Given this list of marker genes DEAF1, CLIP2, UFSP2, ATG7, RPL8, ERCC4, HDAC8, COG1, FBN1, CSNK2A1, LBR, VPS35L, SLC32A1, FLII, EDA, TPM2, ANTXR2, CHRNA1, BSCL2, EHMT1, KMT2D, CUL7, GALNT2 (NCBI Gene Id 2590), ASAH1, CNOT3, SPARC, GABRD, TCF20, VPS37D, COL7A1, DDR2, SLC9A7, SH3PXD2B, GRIN1, KRAS, LRP4, MAN2C1, EVC2, CTSD, IRF6, DSP, SEC24C (NCBI Gene Id 9632), STX1A, FBXL3, KCNAB2, RRAS2, LONP1, UBA2, MOGS, GLB1, IKBKG, TOMM7, FRA10AC1, VPS13B, DMXL2, KLHL15, MECP2, CCNK, WRN, AKT3, PIGS, KIF1A, NKX2-5, HRAS, RREB1, TCF12, PHYH, PGAP3, VAC14, WASHC5, XRCC2, RRAS, ABL1, CEP19, ARID1B, CDKL5, COG8, RPL15, CSGALNACT1, CEP104, SETD2, LMNA, PRMT7, DHCR7, TAF4, SOS2, ZFX, GPC4, LZTR1, HTT, FGFR1, MCTP2, GGCX, BUD23, ZMPSTE24, MYSM1, UBE2T, ARID1A, IGF1, CEP152, GNB1, TUBB3, NAA20, GABBR1, PIGH, ATP7A (ATPase copper transporting alpha), TWIST2, BMPR1B, SVBP, FBLN1, SHH, CDKN1C, IFT122, ATL1, CHST11, ALG12, BRIP1 (NCBI Gene Id 83991), TOPORS, PCNT, HYLS1, DPF2, PQBP1, WDPCP, PPOX, TBX3, CAMTA1, TAF6, OGT, ZFPM2 (NCBI Gene Id 56958), MAPT, WNT5A, NSUN2, CCDC8, TXNDC15, SEMA3E, COG5, DDX11, PCDHGC4, ATR, MKS1 (NCBI Gene Id 54903), HUWE1 (NCBI Gene Id 54789), BUB1B, ASCC3, PTHLH, DLG5, FANCI, SLC25A24, RPL9, IHH, SHMT2, ADA2, GLI3, RAB34, CCDC28B, MPZ, CTNND2, FLNA, FMR1, SPRED1, RPL35, RAB3GAP1, RB1, NEPRO, FGF10, PTDSS1, TRIO, HOXA11, ARMC9, UBAP2L, HHAT, HNRNPK, ARSB, BRAF, KCTD1, IFIH1, OFD1, LHX4, EGR2, ORC1, BBS12, NOTCH1, MAPK8IP3, KPTN, NDN, HIC1 (NCBI Gene Id 3090), WWOX, SRCAP (Snf2 related CREBBP activator protein), CEP55, MMP1, AMER1, CKAP2L, RAB18, KDM6A, DDX59, TUBA1A, GTPBP2, ZNF699, TP63, ANAPC1, WIPI2, MED12, MEN1, SPART, SNORD116-1, TFAP2A, TMEM107 (transmembrane protein 107), ANKRD11, PIGL, B3GAT3, DPAGT1, ROR2, B9D1, TBX5, YWHAE, BRCA1, PRKACA, NALCN, MAPK1, FIBP, PIK3CD, AHSG, TRIP11, BAP1, ARX (NCBI Gene Id 619216), JAG1, ARHGAP31, STX16, ATP6V1B2, KCNJ2, TUBB2B, INSR, IGF2, HMGA2, CANT1, RPS29, COG4, REV3L, GAN, IFT74, GTF2IRD2, PAICS, SH2B1, NEXMIF (NCBI Gene Id 340533), ATL3, CHD8, PUM1, PHF8, FANCA (NCBI Gene Id 82952), GDF1, CNOT2, GABBR2, PPARG, CPLX1, DHPS, SON, PHIP, CDC6, BRAT1 (NCBI Gene Id 221927), WDR73 (WD repeat domain 73), TRAPPC2, CLCN7, SLC25A22, CSPP1, MEG3, CEP290, GJB6, NARS2 (asparaginyl-tRNA synthetase 2, mitochondrial), APC, TBL1XR1, BUB3, EDA2R, LEMD3, WNT7A, WDR26, RERE, CDC42, MATN3, RAD51C, TBX1, B9D2, RAB3GAP2, JUP, NANS, SLC6A17, PALB2, DNA2, GLE1 (GLE1 RNA export mediator), TMEM67 (transmembrane protein 67), GDF5, FANCD2, IQCE, COL9A3, CTBP1, CHD6, SPOP, WDR35, PCGF2, DYNC1H1, WAC, CRELD1, GJA1, UBR1 (NCBI Gene Id 64703), FZD2, ARSL, BBIP1, DPYSL5, EVC, AGO2, MEF2C, TMCO1, DYM, DONSON, AMMECR1, FOXP2, NAA10, MAF, PNKP, ERCC6, ROBO1, HSPG2, DNMT3A, CCDC32, KIF7, SF3B4, PLAG1, C2CD3, H19, SDCCAG8, CTSK, ALOXE3, PIGN, CDC42BPB, WDR81, JMJD1C, DYNC2I1, PSAP, EBP (EBP cholestenol delta-isomerase), PSMD12, INTU, CD96, ATRX, PHEX, NUP37, DCHS1, LMBR1, FLI1, INPP5E, CIBAR1, SOX6, COX4I1, RAB33B, ENPP1, PHOX2A, UBE4B, GJB2, IFT52, SLX4, FIG4, RTL1, PIGF, RUNX2, PTEN, GNAO1, SMARCD1, METTL27, SCN9A, RSPRY1, ASXL3, BHLHA9, BBS7, PTPN2, ZNF462 (zinc finger protein 462), TFE3, SMO, NGLY1, LMX1B, CWC27, SIK3, ARL3, TGDS, RPS7, SOX11, SATB2, TBL2, PAX3, DPH2, RPL5, PIBF1, ALG6, HOXD13, SMC3, GMNN, CTSC, TWIST1, MEIS2 (NCBI Gene Id 56908), DYNC2I2, TRIM32, DYNLT2B, PIGY, FANCM, TELO2, CREBBP (CREB binding protein), CHN1, NTRK1, PRDM16 (PR/SET domain 16), UNC80, RIT1, ALOX12B, TRIM8, FGFRL1, LUZP1, RETREG1, MITF, MKKS, CACNA2D1, BRD4, SCN2A, CAVIN1, PIK3R1 (phosphoinositide-3-kinase regulatory subunit 1), GPX4, GP1BB, TRPM3, NOTCH2, IL2RB, RPS24, RMRP, CBY1, PTRH2, ARCN1, EOGT, H4C3, MRAS, CDK5, PPP1R21, COASY, KCNJ5, PRKACB, SEM1, TBR1, GTF2IRD1 (NCBI Gene Id 9569), COL10A1, ADAMTS10, KDM5A (NCBI Gene Id 5927), MAP3K7, SNORD115-1, KAT8, TREX1, GLI2, KDM4B, NEUROD2 (neuronal differentiation 2), WNK3, SPTLC2, SOS1, RFWD3, ATP6V1E1, SLC52A2, FGFR2, ALG13, LRP5, FGD1, CCDC22, HSD17B4, ORC6, HEATR3, TRPS1, RPS10, RNF216, DOK7, TFAP2B, RYR3, SYNE1, CD247, FAT4, COL2A1, MEGF8, NSD2, ABCA12, GLI1, BBS5, SCN1B, COL3A1, CEP41, TNNI2, FOS, RPS20, NDRG1, STAT4, SMARCA4, CHRNG, NSDHL, RPL10, TCTN3, CNTN1, NPR2, PAFAH1B1, PHGDH, ZIC1, CCBE1, KIT, KIF5C, IQSEC2, RPGRIP1, TBX22, CEP57, NELFA, PWAR1, PLOD3, KCNK4, DYNC2H1, COL9A1, ODC1, PLXND1, GATA6, SBF2, LSS, PLK4, PTPN22, CDC45, MLXIPL, RBM10, SMARCC2, COL17A1, PMP22, LIMK1, NIN (ninein), SLC34A2, MYH3, ACTL6B, GUSB, FGFR3, CHRND, UBE3A, NUP85, ARID2, DACT1, KIFBP, AHDC1, DLX5, HERC1, IFT172, TMEM231, PRG4, USP9X, CAPRIN1, FBXO11 (NCBI Gene Id 80204), PDPN, STAMBP, EIF4A2, KCNH1, BBS4, RBM8A, IGF1R, PTF1A, NCF1, SAMD9, ACP5, GALNS, PHF21A, BRCA2, NPHP1 (nephrocystin 1), SLC35D1, FILIP1, CASK, NOG, PHF6, L1CAM, MYMX, B3GLCT, TBX4, OTUD5, YY1AP1, WNT10B, RPL26, ASPH, KLF13, ELN, CRKL, ABCC6, TMEM237, RAD21, CDH3, AIP, CFAP418, RNF13, SMG9, SF3B2, BGN, GNAS-AS1, KRT1, CCN2, NSD1, FLT4, PIGO, SLC35B2, BBS9, LETM1, ERF, ZNF292, CAMK2G, BBS10, RECQL4 (RecQ like helicase 4), QRICH1, MAP3K20, H3-3B, LHX3, ERCC8, ADGRG6, WDR4, KDR, AKT1, SNRPN, SMARCA2, PRKAR1A, SHANK3, KIAA0753 (NCBI Gene Id 9851), IFT27, CHUK, MADD, KDM5C (NCBI Gene Id 8242), MMP2, ACVR1, BAZ1B, SCYL2, MYBPC1, MBTPS2, PIGV, DNAJC30, PTCH1, KDM6B, FANCG, RIPK4, MAX, BLM, GNAS, EXT2, MACROH2A1, SCNM1, ACOX1, CILK1, RAI1, ABCC9, GNB2, PIK3R2, TBC1D24, KRT5, TGM1, ACTB, HNRNPH1 (NCBI Gene Id 3187), MYMK, KMT2B, MKRN3, MMP23B, NKX2-6, ZMYM2, FERMT1, SCAPER, HOXA13, SMARCB1, MAFB, PIGG, OPA3, RNU4-2, SIN3A, TOR1A, SCARF2, SOX4, SALL4, BCOR, CCND2, STAG1, CLDN16, DPM1, BTRC, ORC4 (NCBI Gene Id 5000), RPS27, EFNB1, GATA4, MBD5, PEX6, BPTF, GNPNAT1, ZNF141, IFT80, ZC4H2, SETBP1, MAGEL2, ADNP, SMAD4, MTOR, COL11A1, LTBP3, DOCK6, SC5D, DHODH (NCBI Gene Id 1723), CTDP1, AHI1 (Abelson helper integration site 1), NTNG1, LMNB2, MORC2, GNPTAB, FANCL, GPR101, AFF4, FBXO28, FLNB, PIGW, PPM1D, ZBTB20, BRF1, IFT57, ATP2B1, RAD51, INPPL1, FGF16, RPL31, SATB1, RPGRIP1L, HINT1, NEDD4L, BICRA, BMP6, ARVCF, BLTP1 (bridge-like lipid transfer protein family member 1), KCNA1, ARL13B, NRAS, SUFU, SIK1, BCR, ALDH18A1, IDS, CTCF, KDM1A, GRIK2, POC1A, CNTNAP1, PPP2R3C, ACBD6, NEK1, POU1F1, ACAN, DYNC2LI1, TNNT3, CBFB, BMP4, CAV1, ERI1, ADAMTS15, CPLANE1 (ciliogenesis and planar polarity effector complex subunit 1), BPNT2, LAMA3, TRIP13, WDR11, EZH2, HNRNPA1, STAG2, FRAS1 (Fraser extracellular matrix complex subunit 1), POR, RNU4ATAC, TRAIP, MMP14, KAT6B, CENPE, ZSWIM6, RASA2, PRKDC, EXOC6B, PACS1, HFE, FANCC (FA complementation group C), COG7, TMEM216, ADAMTSL2 (ADAMTS like 2), PIK3C2A, USP7, PDGFRB, SLC2A10, PROP1, TRPV4, SCUBE3, TGFBR1, SUZ12, BANF1, PTPN11, TMEM218, DVL1, ALDH1A2 (aldehyde dehydrogenase 1 family member A2), MYL11, PIGA, KIAA0586, LZTFL1, PACS2, SDHB, RBPJ (recombination signal binding protein for immunoglobulin kappa J region), AUTS2, GPC3, RECQL (RecQ like helicase), SLC6A9, WDR19, NIPBL, ATRIP (ATR interacting protein), LAS1L, NR4A2, TCF4, EIF4A3, PAH, TPR, RPS19 (ribosomal protein S19), CNOT1, SLC26A2, SDHC, RAB23, EIF2AK3, TBCE, TTC8, GRM7, HSPB1, ITGB6, MIA3, EXT1, PRIM1, HEPACAM, TONSL (NCBI Gene Id 4796), COMT, LAMA5, KIDINS220, MRPS28, RAF1, EXTL3, EN1, RPS6KA3, SIAH1 (NCBI Gene Id 6477), BBS1, LAMC2, KIF21A, AFF2, NFIX, CCDC47, ATN1, DLL4, AGPAT2, CUL3, ESCO2, HESX1, HIRA, EIF4H, PKDCC, TRAPPC9, MSL3, PRR12, PIEZO2, RBBP8, TMEM270, SEMA5A, SIL1, FAM149B1, CDK10, TOGARAM1, MYOD1, SMARCE1, CASZ1, CDH11 (cadherin 11), FBXW4, LTBP2, NKX3-2, HPGD, MED25, POLA1, NXN (nucleoredoxin), RPS28, RPL11, RPS17, SPRED2, MIR17HG, LIFR, ZEB2, HNRNPR, ASNS, RPL18, LTBP1, RPS26, NPR3, TMEM147, SCLT1, GATA1, MUSK, PUF60, KIAA0825, GALC, CRIPT, PLAA, ITGB4, EBF3, FKBP6, MASP1, KMT2A (NCBI Gene Id 79951), PRX, WNK1, PORCN, PWRN1, FANCB, CITED2, ALX1, B3GALT6, DLX6, FANCE, EMG1, TMEM53, FBN2, DST, CHSY1, PEX1, ZMIZ1, SOST, ARL6, MCM3AP, PIGB (NCBI Gene Id 9488), MTX2, MPV17, MGP, MAP1B, KATNIP, ANKRD55, GJA8, OBSL1, TSR2, CLCN3, PIK3CA, CC2D2A, ZIC3, IL2RA, CRLF1, PCYT1A, KCNN3, PNPLA6, MGAT2, SLC35C1, PIGQ, ACTG1, CHST3, FN1, MTFMT, ADAMTS17, MECOM, PTH1R, COL11A2, MAD2L2 (NCBI Gene Id 10459), MYCN, SOX9, RNF2, SMC1A, COL27A1, MAN1B1, CBL, COL9A2, HDAC4 (histone deacetylase 4), IDH1, RSPO2, RBM28, PPP2R1A, NPAP1, NHS, TTC21B, P3H1, RPL27, TBX15, GATA5, JPH1, TMEM94, POLR1A, TCTN1, PI4KA, NUP107, PDE6D, SPEN, ABCC8, DPH1, OCA2, RFC2, MAPRE2, HERC2, ALMS1, PRKG2, GJA5, TMEM138, BUB1, GDAP1, CCNQ, MIR140, BICD2, DLX3, RPS15A, CEP120, KIF22, TRPV3, XYLT1, KL, SPECC1L, GTF2I, SALL1, XRCC4, CDT1, GRB10, PIGP, FANCF, RIGI (NCBI Gene Id 23586), DLK1, KCNJ11, APC2, PEX7, IRX5, SLC39A13, IFT43, SKI, CHD7, CHRNA7, SIM1, LAMB3, SNRPB, EPB41L1, MBTPS1, ZNF423, BMP2, AIFM1, ASXL1, SNIP1, CTU2, LIG4, PRKCZ, RAB11B, ALG9, KIF15, COMP, SRY, PDE4D, AP1G1, SHOX, CUL4B, FGF9, RAC1, UFD1, EP300, POLR3A, HDAC6, SLCO2A1, NEB, KCNJ8, ALX3, UBE3B, NEK9, SMOC1, MAP2K1, TRAF7, PDE3A, EPS15L1, DVL3, TRRAP, NEFL, EFTUD2, RPL35A, ASXL2, SLC10A7, PITX1, FTSJ1, NONO, KNSTRN, COL25A1, TCTN2, EED, PGAP2, VPS33B, NF1, FAM50A, IFT140, BBS2, here is a description of the gene set: Any structural anomaly of the hand. Abnormal hand morphology species: Homo sapiens Human Gene Set: HP_ABNORMAL_HAND_MORPHOLOGY